The following is a description of a gene set: Human Gene Set: GOBP_PYRIMIDINE_DEOXYRIBONUCLEOSIDE_TRIPHOSPHATE_METABOLIC_PROCESS studied in species Homo sapiens The chemical reactions and pathways involving pyrimidine deoxyribonucleoside triphosphate, a compound consisting of a pyrimidine base linked to a deoxyribose sugar esterified with triphosphate on the sugar., and this is the list of marker genes: DUT, CMPK2, TBPL1, TYMS, DTYMK, DCTPP1